Given this list of marker genes NPY2R, LRRK2, S1PR2, CELF4, MIR30B, PRKN, MTMR2, PTEN, NLGN4X (NCBI Gene Id 64642), TMEM25, CBLN1, EIF4A3, here is a description of the gene set: Human Gene Set: GOBP_NEGATIVE_REGULATION_OF_EXCITATORY_POSTSYNAPTIC_POTENTIAL Any process that prevents the establishment or decreases the extent of the excitatory postsynaptic potential (EPSP) which is a temporary increase in postsynaptic potential due to the flow of positively charged ions into the postsynaptic cell. The flow of ions that causes an EPSP is an excitatory postsynaptic current (EPSC) and makes it easier for the neuron to fire an action potential. species: Homo sapiens